The following is a description of a gene set: studied in species Homo sapiens Any process that modulates the frequency, rate or extent of male gonad development. Human Gene Set: GOBP_REGULATION_OF_MALE_GONAD_DEVELOPMENT, and this is the list of marker genes: NR5A1, DHX37, SRY, WT1 (NCBI Gene Id 7490), CITED2, DMRT1 (doublesex and mab-3 related transcription factor 1), ZFPM2, WNT4, SOX9